The following is a description of a gene set: Flaring of rib cage Human Gene Set: HP_FLARING_OF_RIB_CAGE species: Homo sapiens The presence of wide, concave anterior rib ends., and this is the list of marker genes: TRIP11, GALNS, B3GALT6, GLB1, IL1RN, TRPV4, RMRP, GNPNAT1, DYM